Given this list of marker genes NT5DC2, EXT1, NCL, TPX2, TRAF5, IGF2BP2, PABPC1, POSTN, CKS2, PTTG1, IFNGR2, DKC1, IARS1 (isoleucyl-tRNA synthetase 1), LBR, CKAP4, MID1IP1, LRRC8B (NCBI Gene Id 23507), CALU, PPP1CC, H4C3, KHDRBS1, ATP1B3, UBE2C, ELF3 (NCBI Gene Id 2106), ALDOA, EPCAM, GNPDA1, UCHL1, NCAPG, RNF44, KIF15, MMD, TCIM, KIF2C, DDX39A, MARCKS, TUBA1C, ITGA5, NAP1L1, JPT1, ADAM9 (NCBI Gene Id 8754), CSE1L, DRAM1, SMOX, ENO1, TFRC, CAPG, UBR5, ASAP1, MTMR2, ANXA5, YEATS2, RPSA, HILPDA, VIL1, CLIC1, DAB2, CENPE, HIF1A, BZW2, LAMB1, TMEM165, FBL, PRC1, ARPC2, GPX7, HIC2, TMED3, CHD7, BUB1B, RPS3, SPATS2, UGCG, LHFPL2, CENPA, PNMA1, PRSS3 (serine protease 3), SLC12A8, CENPM, SPATS2L, MCM7, P2RX4, VPS37C, TKT, COCH, UBE2I, EIF3H, SLC7A1, PLP2, EPRS1, LRRC1, S100A6, PELI1, CTSC, HK2, UCK2, MYO6, ATIC, HOMER1, BUB1, COL1A1, CDC25A, ARHGEF2, SERPINH1, TTK, CBX3, HMGA2, STK26, ASRGL1, SPINK1, RPL8, GNAZ, KIF23, RACGAP1, LAMC1, VCAN, MMP11, SUCO (NCBI Gene Id 51430), HELLS, OLFML3, NUP62, HEATR1, RALY, ME2, PHLDA2, CDC25B, KDELR3 (KDEL endoplasmic reticulum protein retention receptor 3), ZMIZ1, IGSF3, HGF, HDAC2, MMP12, RAP1GAP, EIF3D, CDK1, TRIP13, GPD1L, TRIM28, INTS8, PTPN12, MMP9, EIF3E (NCBI Gene Id 3646), RAD51AP1, ATP11B, ILF2, TPM2, MCM3, CEP55, BORA, RND3, PSRC1, PRMT1, SSRP1, SLC4A7, PAFAH1B3, CCL20, NRCAM, BLM, RPLP2, DKK1, AGO2, TIMP2, TACC3, SULF1, UBAP2L, CDK4, CAMSAP2, MARCKSL1, KIF11, MAT2A, HJURP (Holliday junction recognition protein), XPNPEP1, BICC1, MAPRE1, LMNB2, BLMH, LPCAT1, TNFRSF21, SERPINE2, PLEKHF2, CORO1C, CXCL8, TOMM20, CSRNP2, KIF20A, CNOT6, JARID2, TROAP, COL4A1, BAMBI, CCT2, DLGAP5, MTHFD2, SALL2, YWHAZ, TSPAN3, SOBP (sine oculis binding protein homolog), SRRT, ZNF532, PHF21A, LAPTM4B, ETV5, S100A11, VNN2, EPS8L3, COL1A2, DLG5, AMD1, NCAPD2, PKM, TTLL4, PDGFRA, TOP2A, MEP1A, SMARCC1, SSB, SOX9, SPAG5, DNMT1, ITGAE, MAPK13, COL5A2, PTK2, NSMAF, STK39, ENPP2, SPP1, PLBD1, G6PD, MMS19, MCM2, SPHK1, INAVA, AGPAT5, TPD52L2, MACROH2A2, NREP, LGALS3, DSG2, ROBO1 (roundabout guidance receptor 1), TMEM184B, SOX4 (NCBI Gene Id 6659), here is a description of the gene set: Genes up-regulated in the stem cell-type subclass of hepatocellular carcinomas. Sets created as part of a metaanalysis of nine public transcriptomic datasets merged into a metadataset including 1133 human hepatocellular carcinomas obtained after curative resection. For platform descriptions of each one of the 9 datasets, see Figure 1B in Désert et al., Hepatology (2017), 66: 1502-1518. Hepatocellular carcinomas (HCCs) exhibit a diversity of molecular phenotypes, raising major challenges in clinical management. HCCs detected by surveillance programs at an early stage are candidates for potentially curative therapies (local ablation, resection or transplantation). In the long term, transplantation provides the lowest recurrence rates. Treatment allocation is based on tumor number, size, vascular invasion, performance status, functional liver reserve and on the prediction of early (< 2 years) recurrence, which reflects the intrinsic aggressiveness of the tumor. Well-differentiated, potentially low-aggressiveness tumors form the heterogeneous molecular class of non-proliferative HCCs, characterized by an approximate 50% beta-catenin (CTNNB1) mutation rate. To define the clinical, pathological, molecular features and the outcome of non-proliferative HCCs, we constructed an 1133-HCC transcriptomic metadata set and validated findings in a publically available 210-HCC RNAseq set. We show that non-proliferative HCCs preserve the zonation program that distributes metabolic functions along the porto-central axis in normal liver. More precisely, we identified two well-differentiated, non-proliferation subclasses, namely Periportal-type (wild-type CTNNB1) and Perivenous-type (mutant CTNNB1), which expressed negatively correlated gene networks. The new Periportal-type subclass represented 29% of all HCCs; expressed an HNF4A-driven gene network, which was down-regulated in mouse Hnf4a-KO mice; were early-stage tumors by BCLC, CLIP and TNM staging systems; had no macrovascular invasion and showed the lowest metastasis-specific gene expression levels and TP53 mutation rates. Also, we identified an 8-gene Periportal-type HCC signature, which was independently associated with the highest 2-year recurrence-free survival by multivariate analyses in two independent cohorts of 247 and 210 patients. Conclusion: Well-differentiated HCCs display mutually exclusive periportal or perivenous zonation programs. Among all HCCs, Periportal-type tumors have the lowest intrinsic potential for early recurrence after curative resection. species: Homo sapiens from publication Désert R, Rohart F, Canal F, Sicard M, Desille M, Renaud S, Turlin B, Bellaud P, Perret C, Clément B, Lê Cao KA, Musso O (PMID 28498607) Human Gene Set: DESERT_STEM_CELL_HEPATOCELLULAR_CARCINOMA_SUBCLASS_UP